The following is a description of a gene set: A cytoplasmic protein complex containing glycogen synthase kinase-3-beta (GSK-3-beta), the adenomatous polyposis coli protein (APC), and the scaffolding protein axin, among others; phosphorylates beta-catenin, targets it for degradation by the proteasome. Human Gene Set: GOCC_BETA_CATENIN_DESTRUCTION_COMPLEX studied in species Homo sapiens, and this is the list of marker genes: SIAH1, AXIN2, CTNNB1, APC2, CTNNBIP1, GSK3A, CSNK1A1, APC (APC regulator of WNT signaling pathway), GSK3B, CACYBP, AXIN1 (NCBI Gene Id 8312), DACT1